Given this list of marker genes LEPROTL1, FAM169A, LTA, EEF2 (eukaryotic translation elongation factor 2), NCK2, LTBP3, ZNF91, KANSL2, NOSIP, LINC00623, STK26, UBASH3A, GPX7, RETREG1, CD7, VILL, KCNA3, NHERF1, RPS17P5, RHBG, MED15 (mediator complex subunit 15), PPOX, GYPC (NCBI Gene Id 2995), ISG20, GSDMB, ALDOC, ITK, GALT, RPS10P5, PASK, TPD52, RPS3, LEF1, GATA3, BCR, PRR5, HNRNPA1, LBH, USE1, RPS6KA5, APBB1, SLC29A2, MATR3, EHD1, SNHG32, ANKRD49, CAMK2G, PCBP4, EEF1G (NCBI Gene Id 1937), RPS25, SAFB2, TCF20, BCL11B, SYNE1, CDC14B, PKIA, ZNF394, BTG1, TSC22D3, RORA, EIF3E, PLEKHB1, DGKD, ICOS, TTN, CAMK4, VIPR1, CD3G, ZEB1, ADD1, URI1, FAM117A, BTN3A2, CDC37L1 (NCBI Gene Id 55664), CCR7, RAD9A, ZBTB25, CD2 (CD2 molecule), CDC25B, GPR18, SPTBN1, PBXIP1, CD6, CD5, PPP3CC, PVRIG, GUSBP11, CYFIP2, NXT1, FGF9 (fibroblast growth factor 9), BUB3, IPCEF1, CD27, ETS1, HLA-J, GCH1, VNN2, HLA-F-AS1, VAMP2, CD3E, CD247, PLSCR3, SH2D1A, PPP2R3B, ZHX2, KLF9, BCL2, ATG16L1, NIPAL3, CCDC59, CBFA2T2, IL32, NACA4P, MAGEH1, KLF12, UXT, INPP4B, RPL27, CD28, ACD, TTPAL (alpha tocopherol transfer protein like), ECSIT, DCAF1, TUT4, CD96, LIG1, TMEM204, TARP, PRKCZ, SF3A2, SPOCK2, CBLL1, XPO6, SYNE2, SAP30L-AS1, CD69 (CD69 molecule), IL11RA, FLT3LG, ACBD4, SGF29, PIK3IP1, FKBP11, SNPH, ARHGEF1, PDE4D, WDR76, CYTH1, DPP4, RPS15, KLHL20, STK17B, SLC25A38, ADPRM, NR4A2, HIVEP2, TBC1D4, TRA2A, PGGHG, CASK, EDF1, SIGIRR, CCS, RNF126, KCNH2, DNAJB1, DOCK9, HERC1, TRAC, IKZF1 (IKAROS family zinc finger 1), EIF3F, LINC00342, HOOK1, TESPA1, DIDO1 (death inducer-obliterator 1), KMT2A, HNRNPA3, CLEC2D, DUSP1, ITM2C, TXK (TXK tyrosine kinase), SNRK (NCBI Gene Id 87229), EIF3H, TNFRSF25, LGI2, RPF1, TCF7, UBA7, CLUHP3, EPHB4, FBXW4, MYLIP, RSAD1, RALGAPA1, TOMM20, WDR19, CCNG1, RPL35A, ABT1, here is a description of the gene set: species: Homo sapiens from publication Abbas AR, Baldwin D, Ma Y, Ouyang W, Gurney A, Martin F, Fong S, van Lookeren Campagne M, Godowski P, Williams PM, Chan AC, Clark HF (PMID 15789058) Immune cell-specific expression is one indication of the importance of a gene's role in the immune response. In order to identify such patterns, we set out to broadly profile gene expression in a variety of immune cells. Human Gene Set: GSE22886_NAIVE_CD4_TCELL_VS_DC_UP Genes up-regulated in comparison of naive CD4 T cells versus unstimulatd dendritic cells (DC).